The following is a description of a gene set: Human Gene Set: HP_PREMATURE_LOSS_OF_PERMANENT_TEETH Premature loss of permanent teeth Premature loss of the permanent teeth. species: Homo sapiens, and this is the list of marker genes: RSPO1, ELANE, CAT, ITGB4, ALPL, LRP4, TP63